Given this list of marker genes PCSK9, LDLR, OPTN, TRAT1, AP1AR, here is a description of the gene set: Human Gene Set: GOBP_NEGATIVE_REGULATION_OF_RECEPTOR_RECYCLING Any process that stops, prevents, or reduces the rate of receptor recycling. species: Homo sapiens